Given this list of marker genes EP300, DDIT3, BBC3, FOXO1, FOXO4, CREBBP, FASLG (Fas ligand), NFYC, BCL2L11, PINK1, NFYB, FOXO3, NFYA, CITED2, STK11, BCL6, here is a description of the gene set: FOXO-mediated transcription of cell death genes Human Gene Set: REACTOME_FOXO_MEDIATED_TRANSCRIPTION_OF_CELL_DEATH_GENES species: Homo sapiens